The following is a description of a gene set: species: Homo sapiens Human Gene Set: REACTOME_MET_ACTIVATES_PI3K_AKT_SIGNALING MET activates PI3K/AKT signaling, and this is the list of marker genes: HGF, MET, GRB2, PIK3R1, PIK3CA, GAB1